Given this list of marker genes Kcnq1, Scn2b, Kcnj8, Dlg1, Kcne2, Kcnh2, Kcnd3, Kcne1, Rnf207, Kcne3, here is a description of the gene set: species: Mus musculus The process in which ions are transported across a membrane such that the ventricular cardiomyocyte membrane potential changes in the direction from the positive membrane potential at the peak of the action potential towards the negative resting potential. Mouse Gene Set: GOBP_MEMBRANE_REPOLARIZATION_DURING_VENTRICULAR_CARDIAC_MUSCLE_CELL_ACTION_POTENTIAL